The following is a description of a gene set: Mouse Gene Set: GOBP_NEGATIVE_REGULATION_OF_MYELINATION studied in species Mus musculus Any process that stops, prevents, or reduces the frequency, rate or extent of the formation of a myelin sheath around nerve axons., and this is the list of marker genes: Mtmr2, Eif2ak3, Tnf, Fig4, Pten, Tmem98, Lpin1, Ifng, Tnfrsf21, Jam2, Ctsc